Given this list of marker genes Adcy8, Prkacb (NCBI Gene Id 18749), Prkcg, Prkar1b, Adcy5, Prkaca, Gna14, Camkk2, Calm1, Pde1b, Prkar2b, Pde1c, Prkca, Adcy7, Camkk1, Plcb3 (phospholipase C, beta 3), here is a description of the gene set: electronically inferred by orthology from the curated human pathway Reactome Pathway: PLC beta mediated events species: Mus musculus This event has been computationally inferred from an event that has been demonstrated in another species.<p>The inference is based on the homology mapping from PANTHER. Briefly, reactions for which all involved PhysicalEntities (in input, output and catalyst) have a mapped orthologue/paralogue (for complexes at least 75% of components must have a mapping) are inferred to the other species. part of: G-protein mediated events